Given this list of marker genes PTPRR, PTPRG, TENM3, PTPN23, CEACAM1, here is a description of the gene set: Human Gene Set: GOBP_REGULATION_OF_HOMOPHILIC_CELL_ADHESION Any process that modulates the frequency, rate or extent of homophilic cell adhesion. studied in species Homo sapiens